The following is a description of a gene set: studied in species Homo sapiens Human Gene Set: GOBP_REGULATION_OF_GOLGI_ORGANIZATION Any process that modulates the frequency, rate or extent of Golgi organization., and this is the list of marker genes: AKAP9, PDE4DIP, EHD3, MAP2K1, RAB33B, ARMH3, MYO5A, RBSN, STX5, CAMSAP3, MAP2K2, CAMSAP2, MAPK1, USP6NL, MAPK3, STX18